The following is a description of a gene set: Human Gene Set: GOBP_LIPOPROTEIN_CATABOLIC_PROCESS species: Homo sapiens The chemical reactions and pathways resulting in the breakdown of any conjugated, water-soluble protein in which the covalently attached nonprotein group consists of a lipid or lipids., and this is the list of marker genes: ABHD17B, CTSD (cathepsin D), ABHD10, APOE, LDLR, APOC2, ATM, LIPA, LYPLA2, ABHD17C (abhydrolase domain containing 17C, depalmitoylase), LYPLA1, APOB, ABHD17A, PPT1, NOTUM